The following is a description of a gene set: from publication Chen Y, Wang X (PMID 31504780) Human Gene Set: MIR1912_3P species: Homo sapiens Genes predicted to be targets of miRBase v22 microRNA hsa-miR-1912-3p in miRDB v6.0 with MirTarget v4 prediction scores > 80 (high confidence targets)., and this is the list of marker genes: UPF1, SMIM10L1, SMURF1, XK, SCN8A, IL20RA, SHROOM3, ERICH1 (NCBI Gene Id 441310), VPS35, DDX17, TMEM64, CDYL2, TNKS2, SIRPA, MRPL33, GSDME, MEF2C, BMAL2, MGAT3, CDC25A, SOX1, LYPD1, CREB1, DYM, CXCR1, ADAM23, ATOH7, MTHFSD, MYCN, RCAN2, ZNF621, GABARAPL2, DNAJA1, UBE2Q2P13, GPRASP3, PCDHB12, RGS8, PBX1, GSTCD, SPCS2, NSUN7, FAR2, ZRANB1, ARID1A, RALA, FDFT1, PCSK9, TFEC, RB1, WRNIP1, RBMS1, ZC3HC1, FOXL1, FAM20A, SON, YTHDF3, SLC25A26, SCEL, SERAC1, JPH3, TEX261, TRAK1, SNRPB2, CMTR1, CLRN1, ZCCHC2, DPP10, KDM7A, SH3BP5L, NQO1, AKIRIN1, CLTC, ADCYAP1R1, SMC4, LRRTM2, ZNF827, MRE11, DYNC1I1, PDLIM7, NPAS3, SOX30, ILDR2, GALNT10, TMED2, TENM2, SMG7